Given this list of marker genes GOLGA8Q, OGN, SLC10A7 (solute carrier family 10 member 7), SLC35A5, CDH12, IQCG (IQ motif containing G), ARHGAP5, HS6ST3, ZFP36L2, VAPA, TCF21, GOLGA8H, EPHA5, RASSF8, TBC1D30, ZNF568, CAPS2, CYBRD1, SEMA3C, CTNNA3, ANTXR2, BECN1, SCN9A, GNPDA2, ANKRD44, RLIG1, NHS, RRP15, NOXRED1, KPNA3, NLRP9, GPC6, TAC1 (NCBI Gene Id 6864), GNGT1 (NCBI Gene Id 2792), GOLGA8R, ZC3H6, WDR33, MAVS, METAP1, ZNF558, NR3C2, MYO1E, YY1, MMRN1, PDE7A, SLC16A14, PLCB1, GABRG2, PAK5, COG6, ZNHIT6, NETO1, SLC19A2, TRUB1, CNTN3, ZNF566, CFAP300, DLG2, MLLT10, FREM2, CLDN11, ZNF506, SEC24A, SOX11 (NCBI Gene Id 6664), CCDC186, GOLGA8J, IGF1R, GUCY1A2, HECW2, PPFIA2, CD2AP, PHF3, HCN1, FKBP5 (FKBP prolyl isomerase 5), CCSER1, MGAT3 (beta-1,4-mannosyl-glycoprotein 4-beta-N-acetylglucosaminyltransferase), DDX46, DLAT, CHAC2, ATP4B, WDR72, TXNDC9, NUFIP2, TRIM33, CDH11 (NCBI Gene Id 1009), RAPGEF5, PTPN4, RAB27B, TMEM87A, GOLGA8T, STX7, STC1, CCNC, TMEM74, DPYD, RAPGEF6, CHCHD3, ZNF711 (zinc finger protein 711), ZNF426, TOX3, RNF180, ZNF224, IMMP2L, SYT1, RGS21, PHF14, ITGB8, CFAP44, RTN3, KNTC1, PTEN, MEGF10, BCHE, GABRR2, TENT5A, RFTN2, LRRC8B, CSRNP3, TRIM13, PHLPP1, DLX2, GOLGA8N, ITGB1 (NCBI Gene Id 3688), ZFAND6, ZBTB44, SHISA9 (shisa family member 9), HSF2, DENND1B, PRSS23, TFPI, SNRPD3 (NCBI Gene Id 6634), CHST9, GPATCH11, FERMT2, SLC16A7, TSPAN13 (tetraspanin 13), VNN1, MREG, FUT9, PIP4P2, MTX3 (NCBI Gene Id 345778), LINGO2, ITM2A, ADGRG6, BPTF, SETDB1, SWSAP1, TBX1, PRICKLE2, GFPT1, CADM2, THAP2, FMC1, ZNF773, HSD3B2, SOS1 (NCBI Gene Id 7838), IL23R, HYLS1, EP300, RAB11A, SCIN (NCBI Gene Id 85477), SPDYA, KCTD9, TSC1, PCLO, STT3A, LMOD2, PCDHB6, MT1B, TMEM47, RORA, PABIR3, USP15, FHIP2A, LRRC34, PRAG1, PAFAH1B2, ANO4, GALNT12, ZNF684 (zinc finger protein 684), RAD21, OSBPL11, GCLM, DYNC1I1, CHSY3, ERCC8, here is a description of the gene set: Genes predicted to be targets of miRBase v22 microRNA hsa-miR-1279 in miRDB v6.0 with MirTarget v4 prediction scores > 80 (high confidence targets). Human Gene Set: MIR1279 from publication Chen Y, Wang X (PMID 31504780) studied in species Homo sapiens